The following is a description of a gene set: Human Gene Set: GOMF_NMDA_GLUTAMATE_RECEPTOR_ACTIVITY A cation channel that opens in response to binding by extracellular glutmate, but only if glycine or D-serine is also bound and the membrane is depolarized. Voltage gating is indirect, due to ejection of bound magnesium from the pore at permissive voltages. species: Homo sapiens, and this is the list of marker genes: GRIN1, GRIN2B (NCBI Gene Id 2904), GRIN3B, GRIN2C, GRIN2D, GRIN2A, GRIN3A